Given this list of marker genes BMPR2, NFIA, HSPH1, ELMO1, ITGA1, DOCK4, ZSWIM6, MAML3, ADGRF5, PREX2, GNAQ, LDLRAD4, GPC5, HIVEP3, FCHSD2, SEC14L1, EMCN, MTSS1, ITGA8, MEF2A, HLA-E, CADPS2, UTRN, DNAJC1, LDB2, ARHGAP26, PRKCA, NKTR, HIPK2, TCF4, SORBS2, ST6GALNAC3, SNED1, ST6GAL1, IGFBP5, MEIS2, MYO1E, RAPGEF4, GPX3, HSP90AA1, NRG3, ANKS1A, AKT3 (AKT serine/threonine kinase 3), LIFR, STARD13, COL4A1, KIAA1217, DYRK1A, TJP1, LIMCH1, MACROD2, PLAT, KALRN, EPAS1, CACNA2D1 (calcium voltage-gated channel auxiliary subunit alpha2delta 1), PITPNC1 (NCBI Gene Id 731962), ZEB1, PEAK1, MBNL1, PIP4K2A, CDH13, DNAJB1, PBX1, EXOC6B, ARHGEF3, SASH1, CALD1, ZBTB16, SHANK3, GNA14, SBF2, ASAP1, RBMS1, HSPA1A, TGFBR2, TTC28, SVIL, MACF1, FMNL2, AKAP12, APP, PAN3, PTPRG, UACA, NTN4, FKBP5, RBMS3, FOS, PRKG1, HERC1, COL4A2, RABGAP1L (NCBI Gene Id 9910), QKI, SMYD3, JMJD1C, IL6ST, PTPRM, EPB41L4A, HIBCH, CEP112, TIMP3, ADGRL2, FLT1 (NCBI Gene Id 2321), TACC1, TEK, FBXL7, HECW2, PTPRB, TMTC1, APBB2, PDE8A, ARL15, ARGLU1, MED13L, DPYD, PLPP1, SYNE1, NCOA1, PLXDC2, PPFIBP1, PIK3C2A, GRB10, PLPP3, SPTBN1, PRKCE, PIAS1, RFX3, LRCH1 (leucine rich repeats and calponin homology domain containing 1), ARHGEF12, CACNA1C, BCAS3, CHRM3, EBF1, NOSTRIN, SLCO2A1, RASAL2, ALDOB, here is a description of the gene set: Human Gene Set: LAKE_ADULT_KIDNEY_C22_ENDOTHELIAL_CELLS_GLOMERULAR_CAPILLARIES studied in species Homo sapiens from publication Lake BB, Chen S, Hoshi M, Plongthongkum N, Salamon D, Knoten A, Vijayan A, Venkatesh R, Kim EH, Gao D, Gaut J, Zhang K, Jain S (PMID 31249312)